Given this list of marker genes PROKR2 (NCBI Gene Id 3733), PEX16, RLIM, SCN2A (sodium voltage-gated channel alpha subunit 2), MMACHC, MRPL12, GJA5, CAMTA1, KCNB1, PRPS1, SAMD12, ITM2B, DNM1L, PLP1, TOR1A, SH3TC2, CP, NIPA1, NR1H4, WFS1, TSHR, NTNG1, COA7, DNMT1, POLG2, SLC19A3, WARS2, CNKSR2, NFE2L2, ERLIN2, HIBCH, ABCB11, MT-ATP8, COQ8A, NR4A2 (NCBI Gene Id 4929), CYP7B1, AP3B2, DNMT3A, GTF2E2 (NCBI Gene Id 2961), SIGMAR1, ATP2B3, TPR, SUFU, THOC2, STX1B, LMAN2L, PMM2, ALDH18A1, MECP2, GGT1, CNTN2, SLC1A3, TMEM240, VAMP1, PSAP, PODXL, SPTLC1, FBXO7, OPA3, LRRK2, PLA2G6, VLDLR, GRIK2, MT-ND2, ATN1, RFC2 (replication factor C subunit 2), GAMT, ARL3, SPTBN2, ADCY5, NOP56, VCP, TPK1, SCN3A, CHCHD2, AARS1, DNAJC19, MORC2, SCO2, PCDH19, LIMK1, ADH1C, GSS, TGM6, NPTX1, TUBB4A, AR, SDHAF2, FRMPD4, SCN8A, FZR1 (NCBI Gene Id 8855), RNU12, SLC6A17, ASAH1, NONO, NEU1, DNM1, CLPB, TBL2, CEP126, TFG, CDK19, KIF7, POU4F1, SEMA6B, ELN, VAPB, TENM4, TMEM70, MYH14, SPTBN1, RORA, MAG, MKS1, SNORD118, MT-TT, PRDX3 (NCBI Gene Id 29017), TPP1, QDPR, MICU1, STARD7, PPP3CA, HPCA, TAT, CASK, GALC, DNAJC6, KCNC1, HCN1 (hyperpolarization activated cyclic nucleotide gated potassium channel 1), PDE6D, VPS13D, ITPR1, PIGN, CC2D2A, VHL, FEZF1, SPR, PNKP, GPAA1, RPGRIP1L, AFG3L2, DALRD3, SEMA3A, SIK1, SLC25A22, KCNC2, BUD23, MME, PDHA1, TARS1, TMEM270, ADGRV1, TRIO, GRIN2D, FUS, POLR1A, ATP6AP2, POLG, TMEM67, ERCC5, RPL10, CHCHD10, SLC6A19, WDR11, ATP8B1, SLC25A46, KIF1B, CYB5R3 (NCBI Gene Id 1727), SLC32A1, ARX, RTN2, SMN2, TRAPPC6B, FGF13, TNPO2, PRNP, SDHD, LAMA1, NKX6-2, KNSTRN, LEMD2, RNASEH2B (ribonuclease H2 subunit B), GBA2, PIGP, IMPDH2, TRAPPC11 (trafficking protein particle complex subunit 11), TRMT5, PMP2, AIFM1, MT-ND4L, PINK1, CA8, VWA3B, CBY1, INPP5E, PARS2, VPS13A, APTX, GRM7, GABRB2, ADA2, MED11, TOPORS, CRAT, TTR, KCNN2, SCARB2, NEXMIF, NSD1, KIAA0586, EIF4H, GNAO1, ABHD12, SYNGAP1, PIGQ, COL6A3, ANO3, TMEM237, PIGA, YY1, HMGA2, GTF2I, MTFMT, SMN1, STUB1, PHIP, DAB1, FLVCR1, TNFSF11, REEP2, IFRD1, PTEN, GBA1, CARS1, CTH, TNNT1, UBAP2L, PGK1, KMT2B, SDHA, SATB1, ATP1A2, GTF2IRD2, NAXE, CCDC141, ADAMTS13 (ADAM metallopeptidase with thrombospondin type 1 motif 13), LMNB1, MPZ, PTS, SPG11, PPP2R2B, GABRA1, POLR1C, MT-CO3, ELOVL1, SLC38A3, MEN1, CSPP1, REPS1, PRKCG, CLN5, MAPT, SNRPN, CEP104 (NCBI Gene Id 9731), MT-ND5, JPH3, SLC39A14, FOXG1, CCDC88C, CLTC, TSPOAP1, SAMHD1, SMG9, MARS1, MYO5A, UCHL1, NEFL, FLRT3, TSFM, NCF1, CHD2, PMPCA, IVD, NTNG2, UROC1, PDGFB, DDC (NCBI Gene Id 9492), ATP7B, SPRY4, SCN1B, COQ2, CHD7, MSTO1, RNASEH2C, PPP1R15B, SYNJ1, APC2, VRK1, CDKL5, ENSG00000288330, MT-ND6, CACNA1A, SPEN, C19orf12, ADPRS, GRIN1, MMAA, RNU7-1, KCND3, KATNIP, TOGARAM1, EPRS1, AASS (NCBI Gene Id 10157), SLC18A2, QRICH1, PDE8B, FTL, FGF14, AKT1, ELOVL5, SCP2, NFASC, ATXN10, FH, MT-TL1, TAF1, POLR3A, SETX, HSD17B4, THG1L, ATP6V1A, STX1A, DHDDS, CYFIP2 (cytoplasmic FMR1 interacting protein 2), MPLKIP, VPS13C, ATP13A2, PROK2, CLCN7, DDOST, KIAA0753 (KIAA0753), GTF2IRD1 (GTF2I repeat domain containing 1), BAZ1B, MAN1B1, NDNF, ERCC6, UQCRC1, TMEM127, SGCE, NGLY1, GABRG2, PANK2, SMC1A, CAPRIN1, TH, CTLA4, OPA1, CSTB, SCYL1, HTRA2, HMBS, TK2, RNF113A, DLST, DPM1, ZNF142, CEP41, XPNPEP3, CLCN2, GOSR2, PRKAR1B, NPHP1, EIF2AK2, PITRM1, SLC13A5, SLC20A2, PEX10, PIK3CD, CELF2, ATCAY, IFT74, ERCC3, NTRK2, CTDP1, NKX2-1, KCNK4, GABRD, CTC1, DARS2, BRAT1, HSPD1, HYLS1, RRM2B, FBXO28, PIK3CA, ATXN3, UBA5, GTPBP2, RILPL1, KCNA1, CTNND2, PDGFRB, PIBF1, NDUFS2, NOL3, GABBR2, CYP27A1, ANO10, MT-ATP6, LEMD3, ANOS1, ARMC9, RAB39B, KCNA2 (potassium voltage-gated channel subfamily A member 2), SLC30A10, VPS35, NECAP1, ABCB7, SLC1A2, WDR45, CLIP2, NGF, ATP1A3 (ATPase Na+/K+ transporting subunit alpha 3), ALS2, SLC25A13, CACNA1S, GTF2H5, LSM11, TMEM231, PEX2, PTRHD1, VPS37D, TWNK, AP2M1, RAB3GAP2, FAM149B1, SLC6A3, ADRA2B, LRPPRC, SLC12A6, TTC19, SLC9A1, GIGYF2, ARSA, GRIA3, TPI1, ABCB4, GABRA3, NEUROD2, FKBP6, AARS2, ATM, GPT2, TMEM106B, DMXL2, IL17RD, TRIM8, RARS1, TREX1, SACS, METTL27, TMEM218, PRKN, ACBD5, NARS1, TACR3, TTPA, COQ4, PRDX1, KCNJ10, PNPLA6, BSCL2, MRE11 (MRE11 homolog, double strand break repair nuclease), MARCHF6, OPHN1, PUS7, KCNC3, TIMM8A, TNFRSF1B, CD28, SQSTM1, FGF12, CACNA2D1, PAH, MT-CYB, ACBD6, SNX10, TCTN3, GALT, CLTRN, CACNA1B, HTT, ATXN7, OFD1 (NCBI Gene Id 8481), SOX10, SZT2, CACNA1G (calcium voltage-gated channel subunit alpha1 G), SDHB, HYCC1, MAX, TBC1D24, DCTN1, PNP (purine nucleoside phosphorylase), WWOX, SFXN4, EPAS1, YEATS2, PARK7, PCBD1, FARS2, FGF17, ATXN2, HS6ST1, PMP22, MYBPC1, PRRT2, MYL2, SLC39A4, GRM1, DCC, PTPA, WDR81, EEF1A2, RFC1, PDE10A, TMEM222, PRICKLE1, CARS2, HEXB, SBF2, ERCC2, CUL4B, YWHAG, TCTN1, UBE3A, RNASEH2A, CPLANE1, ABCB6, UGT1A1, FGFR1, MAOA, ZFR, GJB1, AMACR, OXR1, TRAK1, MRPS34, TMEM216, TCIRG1, LNPK, ZFYVE26, PEX6, NF1, PACS2, DNAJC30, GJA8, SCN9A, CDC42BPB, PRORP, MFN2, ATXN8OS, SDHC, ELOVL4, ARL13B, MT-ND4, OCA2, AHI1, ATXN1, NUS1, B9D2, MDH2, HESX1, TMCO1, CWF19L1, GCDH, FXN, UFC1, SNCA, NUTM2B-AS1, TCTN2, TMEM63A, GCH1, SLC6A1, DNAJC13, PDYN, GABRA5, RET, GABRA2, DUSP6, ATG7, ASL, MT-ND1, ERCC8, PRKRA, KARS1, CTSF, HNF4A, MT-CO1, FGF8, ASNS, GCK, JAG1, ERCC4, KCNJ18, LRP12, KIF1C (NCBI Gene Id 9713), NEMF, DPAGT1, CEP120, CIZ1, TECR, UBE3C, SLC25A4, SLC25A11, FMR1, GJC2, SLC2A1, SNCAIP, POLR3B, ADAR, NOTCH2NLC, IFIH1, STXBP1, COQ5, PIK3R5, ACTL6B, CACNA1C, NDRG1, B9D1, SCN1A (NCBI Gene Id 6323), BEAN1, CDH23 (cadherin related 23), TBP, EIF4G1, SLC5A7, PDK3, PI4KA, LYST, ITPA, PGAP1, DRD3, here is a description of the gene set: studied in species Homo sapiens Human Gene Set: HP_TREMOR An unintentional, oscillating to-and-fro muscle movement about a joint axis. Tremor